The following is a description of a gene set: Human Gene Set: HP_EXERCISE_INDUCED_MYALGIA Exercise-induced myalgia The occurrence of an unusually high amount of muscle pain following exercise. species: Homo sapiens, and this is the list of marker genes: MYF6, TRIM32, FLNC, PGAM2, TMEM126B, MTMR14, MLIP, SLC25A42, RNASEH1, DYSF, AMPD1 (NCBI Gene Id 270), BIN1, LMNA, LPIN1, DNM2, PHKA1, HMGCR, MT-CO3, MATR3, STIM1, ACADVL, PFKM, PYGM, FILIP1, TPM2, RYR1, RRM2B, LDHA, MT-CO1, HNRNPA1, AMPD3, ANO5, ACADM, CAV3, CPT2, PGK1, OBSCN, PMP22